Given this list of marker genes KIF3B, RBCK1, VAMP2, DHX57, RIMS4, FJX1, TNFSF12, SEPTIN7, DFFB, BCAS3, KMT5A, here is a description of the gene set: Genes having at least one occurence of the motif GGATCCG in their 3' untranslated region. The motif represents putative target (that is, seed match) of human mature miRNA hsa-miR-127 (v7.1 miRBase). Human Gene Set: GGATCCG_MIR127 species: Homo sapiens